The following is a description of a gene set: studied in species Homo sapiens Human Gene Set: GSE339_CD4POS_VS_CD4CD8DN_DC_IN_CULTURE_UP from publication Edwards AD, Chaussabel D, Tomlinson S, Schulz O, Sher A, Reis e Sousa C (PMID 12816982) Genes up-regulated in comparison of CD4 dendritic cells (DC) versus CD4- CD8- DCs. The functional relationships and properties of different sub-types of dendritic cells (DC) remain largely undefined. We used a global gene profiling approach to determine gene expression patterns among murine splenic CD11c high DC subsets in an effort to better characterise these cells., and this is the list of marker genes: ELOVL1, ZCCHC3, TMEM183A, CTNND2, TCF7L1, ACTN2, GALC (galactosylceramidase), CD164, PPARGC1A, HIF1A, FER, R3HDM1, YES1, ANK3, TMEM167A, CR1L, DPEP1, SPAG5, MZT2B, PHLDA3, B3GNT2, SEMA5A, FGF5, IGFBP6 (NCBI Gene Id 3489), TAF9, PDCD2, ACE2, SGCA, ZNF808, PLAC9, RAC1, NPTX1, POLG2, PRM3, CFL2, CD6, GPCPD1, IRS2, SHOC2, RBP2, CCNB1IP1, AFF2, CD276, CHRM4, UBE2D3, TCF12, SLC25A47, KEAP1, RETREG2, P3H3, TPP1, HSPH1, EHF, HMGB4, DYNC1I1, SMTN, NCOA2, RPL31, MNS1, TNFRSF4, RPS27, NUFIP1, MYH1, NAA30, MAP3K6, UTS2R, CNOT6L, TM7SF3, CETN1, SDC2, POLR3D, TKTL1, PLA2G4A, CLEC4D, IVNS1ABP (influenza virus NS1A binding protein), GAP43 (NCBI Gene Id 2596), FANCG, SLC51A, FOXO4, GBE1, IGFBP7, TYK2, MRPS31, ADORA2B, FHDC1, MGAT3, EPHA3, PTCH2, HAUS4, DMP1, ALOX15, MMP12, ZRSR2, POLG, ADAM10, ACP5, HNRNPU, LENG8, NDN, GPR143, BHMT, LIPA, ITGAV, NAMPT, AADAC, RPTN, NDUFAF4, PTPRB, KLHDC2, ERBB4, PLK2, WTAP, BIRC6, MATN2, USP14, IRS1, VAPA (NCBI Gene Id 9218), HAPSTR1, C11orf16, NEUROD2, LYSMD1, WWC1, DTD1, ICAM5, EREG, WSB1, PLGRKT, APLP1, PNPT1, TENM1, ABHD8, ADRA2B, TCIRG1, IDUA, IL1R2, KLHL7, MIS18A (MIS18 kinetochore protein A), MZF1, CUZD1, SPINK4, SNCA, PEX7, DVL3, TSHR, ZYG11B, GUCA2A, KRTAP19-5, UTP20, COMMD5, ERCC4, HMCES, TCF25, CX3CL1, FBXL5, NR1D2, PKN2, CFAP184, RAPSN, RAG2, BTG4, PNPO, TUBA3C, CTSZ, MOS, RPAP3, IL9R, H1-3, CBX3, RLBP1 (NCBI Gene Id 6017), ZNF354A, CDHR5, ADIG, IDH3B, INHBC, USP29, MRPS34, GREM2, KIF3C, FUT2, DCUN1D2 (NCBI Gene Id 56234), EIF3E, SPRTN, AZIN1, CDO1, DDHD1, BPNT2, GFI1, EML5, TSPAN13, ZNF746, DPF3, ISLR, TOP1, FEM1B, TAMM41, HAS1, TPGS1, LINC00612, CMKLR1, PTAFR